The following is a description of a gene set: studied in species Homo sapiens Triggered by acidification of the endosome, insulin dissociates from the receptor and is degraded. The receptor is dephosphorylated and re-integrated into the plasma membrane, ready to be activated again by the binding of insulin molecules. part of: Signaling by Insulin receptor Reactome Pathway: Insulin receptor recycling, and this is the list of marker genes: TCIRG1, ATP6V0A4, IDE, ATP6V1D, ATP6V0A1, ATP6V0D2, INS, ATP6V0D1, ATP6V1B1, ATP6V1C1, ATP6V1C2, ATP6V0A2, PTPN1, ATP6AP1, INSR, ATP6V1E2, ATP6V1B2, ATP6V0C, ATP6V0B, ATP6V0E1, ATP6V1H, ATP6V1E1, ATP6V1F, PTPRF, CTSD, ATP6V0E2, ATP6V1G1, ATP6V1G2, ATP6V1A, ATP6V1G3